The following is a description of a gene set: Any process that activates or increases the frequency, rate or extent of the transport of proteins from the Golgi to the plasma membrane. studied in species Homo sapiens Human Gene Set: GOBP_POSITIVE_REGULATION_OF_GOLGI_TO_PLASMA_MEMBRANE_PROTEIN_TRANSPORT, and this is the list of marker genes: ACSL3, CNST, ATP2C1, RACK1, CLN3, ANXA13